The following is a description of a gene set: Human Gene Set: GOBP_REGULATION_OF_CRISTAE_FORMATION Any process that modulates the frequency, rate or extent of cristae formation. species: Homo sapiens, and this is the list of marker genes: OMA1, MICU1, CHCHD10, PINK1, ADCK1 (aarF domain containing kinase 1)